Given this list of marker genes HEG1, ING4, CLN5, ARIH2, PDE3B, PDE8A, VPS52, RPL34 (NCBI Gene Id 6164), PRRG1, LYST, AKAP6, MCAT, CAPZA2, COX15, EIF4E2, GAA, B4GALT7, POLR1C, SASH1, PINK1, EEF1A1, EML4, TTF2, CLIC4, CAV2, GAPVD1, VPS13D (NCBI Gene Id 55187), NCOR1, WIPI2 (NCBI Gene Id 51623), ALDH1B1, NEK11, OSBPL1A (oxysterol binding protein like 1A), MICU1, IFI16, CADM1, APBB2 (NCBI Gene Id 323), here is a description of the gene set: Genes down-regulated in uterine fibroids with deletions in the 7q region vs those without the deletion. Human Gene Set: VANHARANTA_UTERINE_FIBROID_WITH_7Q_DELETION_DN Uterine fibroids are some of the most common tumours of females, but relatively little is known about their molecular basis. Several studies have suggested that deletions on chromosome 7q could have a role in fibroid formation. We analysed 165 sporadic uterine fibroids to define a small 3.2 megabase (Mb) commonly deleted region on 7q22.3-q31.1, flanked by clones AC005070 and AC007567. We also used oligonucleotide microarrays to compare the expression profiles of 10 samples of normal myometrium and 15 fibroids, nine of which displayed 7q-deletions. Activating transcription factor 3, patched homolog (Drosophila), homeo box A5, death-associated protein kinase 1, and retinoic acid receptor responder 3 were downregulated, and excision repair crosscomplementing 3, transcription factor AP-2 gamma and protein kinase C beta 1 were upregulated in fibroids. New pathways were discovered related to fibroid formation. The presence or absence of 7q-deletions did not dramatically affect the global expression pattern of the tumours; changes, however, were observed in genes related to vesicular transport and nucleic acid binding. from publication Vanharanta S, Wortham NC, Laiho P, Sjöberg J, Aittomäki K, Arola J, Tomlinson IP, Karhu A, Arango D, Aaltonen LA (PMID 15940248) species: Homo sapiens